Given this list of marker genes LIN28B, ENSG00000243273, HSD11B2, DLX4, MSX1, ZNF616, EPHA1, APOB, SEMA5B (semaphorin 5B), RTN4IP1, TXNDC15, SEMA7A, ZNF268, SDC1, PCGF1, LINC01535, SUPV3L1, CYP11A1, PPAT, TNFRSF12A, CCDC192, ZDHHC16, TFAM, GABPB1, NOP14-AS1, NKIRAS1 (NFKB inhibitor interacting Ras like 1), GTF2H2, PLCE1-AS1, C21orf91, ETAA1, CYTH3, CABYR, UPP1, NFU1, CNOT3, CEP152, P2RY11, USP14, CTSL, ZNF587, SPIRE2, HSD17B1, ZNF703, CNNM3, ALG2, RNF14, CYP19A1, SH3GLB2, ZNF280C, HARS1 (histidyl-tRNA synthetase 1), EFCAB8, POU6F1, SLC6A4, CDKN1C, SLC16A4, PREB, SPINDOC, SLC35B2, RPL13AP5, PLAC1, LVRN, CHODL, SEMA3B, MMP11, CGA, MSH6, GPAM, LRP2, ANKRD40, TIMM17A, KISS1, CCNDBP1, POLR2D, ENSG00000261632, TFPI2, TRMT61A, UNC119, TGM2, TRPV6, PPIL2, PEG3, LINC00689, PHLDA2, SLC25A32, C15orf40, AKR1B1, ZNF839, KAT7, WAPL, ALKBH2, CSH2, GPATCH11, EML2, LLGL1, FAM200A, CERCAM, ZNF333, USP43, EED, QNG1, L3MBTL1, ALKBH8, DDIT3, ACO1, TMEM101, ZNF343, LSM10, VPS16, RAC3, SLC2A1, HNRNPD, ZNF880, A2M-AS1, EBI3, TIPIN, DLX3, EVA1B, CENPV, EFHD1, DOLK, TMEM192, PSG5, ZNF74, CNKSR1, TCAF2P1, SLC25A35, TSEN34, SYDE1, ASF1A, BOK, KMO, PGP, TIMM50, MFSD13A, TTPAL, VGLL3, SPTLC3, PAPPA, ZFYVE28, GNGT1, STARD4, COBLL1, ENPEP, SLC13A4, TARS1, TFPT, PEX12, CARNMT1-AS1, MRGPRF, COQ7, TRAFD1, COPS9, NUFIP2, STRA6, ZFAND1, P2RY2, ILF2, PGF, CCAR2, SEC61G, TEX261, SGPP1, ZBTB14, ADAM12, SLC39A9, ZNF138, UBL7-DT, POLR2J2, KCNJ14, MIR3171HG, OGDH, CHD8, ANGPTL4, METTL5 (NCBI Gene Id 29081), P2RX4, ATXN1L, SLC23A3, LGR5, TM2D2, HSF2, TP53I13, BBOX1, LZTS2, YKT6, SNAI1, ST3GAL4, CDO1, PSMD3, MIR4300HG, TBC1D24, MTMR10, MAP3K12, MARCHF9, RNF128 (NCBI Gene Id 79589), DHX32, SEMA3F, PRDM11, MBD6, NHLRC1, TBCEL, FXN, UEVLD, ANGPT2, SLC52A1, TPTEP1, FAM131A, TWIST1, CYP1B1-AS1, PSG1, HNRNPA1L3, RAB23, SNRPA1, MFSD12-AS1, here is a description of the gene set: The gene expression program underlying the specification of human cell types is of fundamental interest. The study authors generated human cell atlases of gene expression and chromatin accessibility in fetal tissues. For gene expression, the study authors applied three-level combinatorial indexing to >110 samples representing 15 organs, ultimately profiling ~4 million single cells. The study authors leveraged the literature and other atlases to identify and annotate hundreds of cell types and subtypes, both within and across tissues. Our analyses focused on organ-specific specializations of broadly distributed cell types (such as blood, endothelial, and epithelial), sites of fetal erythropoiesis (which notably included the adrenal gland), and integration with mouse developmental atlases (such as conserved specification of blood cells). These data represent a rich resource for the exploration of in vivo human gene expression in diverse tissues and cell types. Human Gene Set: DESCARTES_FETAL_LUNG_CSH1_CSH2_POSITIVE_CELLS from publication Cao J, O'Day DR, Pliner HA, Kingsley PD, Deng M, Daza RM, Zager MA, Aldinger KA, Blecher-Gonen R, Zhang F, Spielmann M, Palis J, Doherty D, Steemers FJ, Glass IA, Trapnell C, Shendure J (PMID 33184181) Marker genes curated from the annotated cluster as represented in the Descartes Human Gene Expression During Development database. studied in species Homo sapiens